Given this list of marker genes CFLAR, BMP4, PDGFA, PDGFD, ITGB3, MIR125A, BMP7, PDGFB, WT1, SERPINB7, EGR1, PDGFRB, IL6R, here is a description of the gene set: The multiplication or reproduction of glomerular mesangial cells, resulting in the expansion of the population. Human Gene Set: GOBP_GLOMERULAR_MESANGIAL_CELL_PROLIFERATION species: Homo sapiens